The following is a description of a gene set: part of: Fc epsilon receptor (FCERI) signaling This event has been computationally inferred from an event that has been demonstrated in another species.<p>The inference is based on the homology mapping from PANTHER. Briefly, reactions for which all involved PhysicalEntities (in input, output and catalyst) have a mapped orthologue/paralogue (for complexes at least 75% of components must have a mapping) are inferred to the other species. species: Mus musculus electronically inferred by orthology from the curated human pathway Reactome Pathway: FCERI mediated Ca+2 mobilization, and this is the list of marker genes: Itk, Syk, Lcp2, Shc1, Lat, Ms4a2, Ppp3r1, Plcg2 (NCBI Gene Id 234779), Fcer1a, Calm1, Vav1, Tec, Grb2, Grap2, Igll1